The following is a description of a gene set: Genes up-regulated in comparison of dendritic cells (DC) stimulated with poly(I:C) (TLR3 agonist) at 4 h versus DC cells stimulated with CpG DNA (TLR9 agonist) at 4 h. from publication Amit I, Garber M, Chevrier N, Leite AP, Donner Y, Eisenhaure T, Guttman M, Grenier JK, Li W, Zuk O, Schubert LA, Birditt B, Shay T, Goren A, Zhang X, Smith Z, Deering R, McDonald RC, Cabili M, Bernstein BE, Rinn JL, Meissner A, Root DE, Hacohen N, Regev A (PMID 19729616) Human Gene Set: GSE17721_POLYIC_VS_CPG_4H_BMDC_UP mouse primary BMDCs were stimulated with tlr ligands and gene expression changes were profiled on Affymetrix arrays species: Homo sapiens, and this is the list of marker genes: H2AC25, SP110, RAB9A, APAF1, HASPIN, TSNAX, RB1, S100A11, RPP21, DHX57, C11orf68 (NCBI Gene Id 83638), ULK2, METTL22, PARP1, TPRG1L, MISP, RAP1GAP, ATG5, AKR1E2, SGK1, SMC3, SMC6, RPL38, NAGA, SNAP47, ATP6V1D, ANAPC4, HLTF, HORMAD1, RPL37A, SESN2, SERINC3 (serine incorporator 3), CEBPA, RPS6, SNHG8, CEP68, RPA1, DTX3, DUSP6, MEF2D, TMLHE, DPYSL5, YTHDF1, XYLB, CHMP1A, COMMD9, PPDPF, FGF13, HES6, SELENOW, BCL2L14, NIPSNAP1, TJP2, MYCL, TPGS1, ME2, CBR1, ABCG1, RPS11, DNAJC12, SMIM3, OLIG2, RTCB, DAPP1, RBM25, ARHGAP5, CEP57L1, PDXK, RCHY1, KIF2A, PELO (NCBI Gene Id 53918), LEFTY1, ANAPC16, VPS26B, EPS8L2, HFE, ING2, MINK1, RPS21, PLAC8, CALHM2, AIF1, HELB, TLR3, PRR15, MINPP1, DOLPP1, ACADS, RPL28, CTNNB1, METTL25B, COMT, PLPP7, SRPK2, TUBA1B, CAMK1D (calcium/calmodulin dependent protein kinase ID), NEMF, FIG4, IARS1, SORL1, HTATIP2, FZR1 (NCBI Gene Id 8855), KLRK1, SH3BGRL3, ANKIB1, BARD1, IGDCC3 (NCBI Gene Id 9543), EEF1G, EXOC7 (exocyst complex component 7), KIF1B, ORAI1, ZNF823, TEX261, RACK1, RNF187, PSIP1, DBR1, PSRC1, PAICS, CCR1, FAM98C, DBNL, SLC46A3, COLGALT1, RELL1, TRAPPC14, DNAJC10, PGAP6, GCLC, BID, FAU, STAB1, PTGER3, NDUFC2, RPSA, ODR4, TOMM70, BIRC2, MXI1, PARP2, OLFM1, VOPP1, SMARCD2, ZDHHC3, STMN1, MIA2, NCBP2AS2, CDT1 (chromatin licensing and DNA replication factor 1), SERF2, FUCA1, WBP1, NPEPL1, ERMP1, BLTP3A, PJA2, ETV3, TMEM14C, NCF2, HMGB1, CCR7, CD8A, FRYL, RALBP1, KEAP1, PIPOX, IL7, MRPL39, PCDH8, IRF1, FANCL, GATA3, MRPL58, PNPLA8, TSPAN13, POLR2E, B9D2, MIDN, WNT11, WIF1, ASNS, KLF2, NICN1, MRPL2, SECTM1, CHCHD7, TSPAN14, LIG1, FNBP1, CCND3, CPSF3, RMC1, CSNK1D, PLXDC2, XPOT, FAM120A, GAB1, PEX11B, ZBTB25, PELI2, DENND4C